Given this list of marker genes UBE2V2, TAC1, SLC38A9, GIMAP5, ARL13B, ALDH9A1, SYNPR, LHX6, NT5C3A, CCDC126, SPINK2, TREM2, VIP, TMEM35A, PIK3R3, IARS1, PTEN, TBC1D8B, SEMA3G, SLC35B3, ATP6AP2 (ATPase H+ transporting accessory protein 2), NDFIP2, KTN1, SLC16A3 (solute carrier family 16 member 3), ZNF185, CXCL13, MPC1, FABP4, SMPDL3A, AOC3, TYROBP, SPRYD7, SDCBP, CASP4, AMY2B, SLC26A11, VWA5A, NTAN1, FGFBP3, FLVCR1, SBDS, ACAT1, QPCT, ASPN, SMURF2 (SMAD specific E3 ubiquitin protein ligase 2), CPA3, FNDC1, USP16, CSTA (cystatin A), ZNF501, RHOJ, GIN1, MYO1C, LRRC75B, DIXDC1, TIPIN, PSMC6, AGL, PFAS, COLEC12, DEPDC1, TEX30, RIC8A, SESN1, PRKCB, HNRNPLL, OGN, CAV1, FGF18, NCL, MTERF2, MED21, IFRD1, GPR182, DVL1, RNF130, TRAPPC2, SLC1A3, LY96, CAVIN2, SYNCRIP, PTGDR2, SPPL2A, SSR1, RAMAC, CNIH1, SERINC3, NMB, GBE1, SLC35A5, RPS6KB1, AGBL3, SCYL3, FAP, EIF2AK2, B2M, B3GALNT1 (NCBI Gene Id 8706), DOCK11, HNRNPDL, HDC, PLGRKT, ODF2L, EBAG9, ZNF639, ZNF318, SMG7, SGCE, C1GALT1C1, VEGFD, PAIP1, MMRN1, TMEM126A, PDCD10 (programmed cell death 10), NUP58, TLE1, RNF11, ACYP2, PRKD3, LRRC17, CFTR, SLC7A3, HPRT1, ARRB2, PTGS1, NAB1, ATRNL1, CASP12, C5orf34 (chromosome 5 open reading frame 34), LEMD3, SPOPL, CAST, FAM177A1, MS4A6A, UBQLN2, EGFR, MARCHF5, ADAMTS2, ORC6, C8orf34, CTSO, GCLC, ZNF670, MBD1, PLEKHS1, KLF9, SLC25A12, SP110, CCDC32, CD300C, GFPT1, EIF2S2, CALCA, SPARCL1, PIAS2, CLEC14A, P4HA2, SFXN3, PTPRB, here is a description of the gene set: from publication Schaeffer EM, Marchionni L, Huang Z, Simons B, Blackman A, Yu W, Parmigiani G, Berman DM (PMID 18794802) Genes up-regulated in the urogenital sinus (UGS) of day E16 females exposed to the androgen dihydrotestosterone for 6 h. studied in species Mus musculus Human Gene Set: SCHAEFFER_PROSTATE_DEVELOPMENT_6HR_UP Cancer cells differentiate along specific lineages that largely determine their clinical and biologic behavior. Distinct cancer phenotypes from different cells and organs likely result from unique gene expression repertoires established in the embryo and maintained after malignant transformation. We used comprehensive gene expression analysis to examine this concept in the prostate, an organ with a tractable developmental program and a high propensity for cancer. We focused on gene expression in the murine prostate rudiment at three time points during the first 48 h of exposure to androgen, which initiates proliferation and invasion of prostate epithelial buds into surrounding urogenital sinus mesenchyme. Here, we show that androgen exposure regulates genes previously implicated in prostate carcinogenesis comprising pathways for the phosphatase and tensin homolog (PTEN), fibroblast growth factor (FGF)/mitogen-activated protein kinase (MAPK), and Wnt signaling along with cellular programs regulating such 'hallmarks' of cancer as angiogenesis, apoptosis, migration and proliferation. We found statistically significant evidence for novel androgen-induced gene regulation events that establish and/or maintain prostate cell fate. These include modulation of gene expression through microRNAs, expression of specific transcription factors, and regulation of their predicted targets. By querying public gene expression databases from other tissues, we found that rather than generally characterizing androgen exposure or epithelial budding, the early prostate development program more closely resembles the program for human prostate cancer. Most importantly, early androgen-regulated genes and functional themes associated with prostate development were highly enriched in contrasts between increasingly lethal forms of prostate cancer, confirming a 'reactivation' of embryonic pathways for proliferation and invasion in prostate cancer progression. Among the genes with the most significant links to the development and cancer, we highlight coordinate induction of the transcription factor Sox9 and suppression of the proapoptotic phospholipid-binding protein Annexin A1 that link early prostate development to early prostate carcinogenesis. These results credential early prostate development as a reliable and valid model system for the investigation of genes and pathways that drive prostate cancer.